The following is a description of a gene set: Human Gene Set: MODULE_301 studied in species Homo sapiens Genes in the cancer module 301., and this is the list of marker genes: HDAC9, ABCC5, GLRA3, IL24, BLOC1S5, COA7, ZNF423, KLHL41, NACAD, MED12L, SELP, PRKCB, NEK11, ZNF395, ANKRD28, FCRL1, TSPOAP1, SPRR1A, ZFP36L2, TCL1A, KIAA0753, FADS3, NTRK3, PLAC8, ADGRE2, MTBP, TASL, HEATR6, SPPL2A, ATP2A3, CSMD2, PTPRO, FLRT2, RSAD2, IGHG3, TRAF3IP3, UNC5D, TAP1, RIPOR3, RAX2, SEL1L, IRF8, TCF7, CD24, VANGL1, IGHM, KCNQ5, BACH2, GABBR1, SPINT2, NR2E1, OAS1, BCL2, PORCN, SLC27A5, FCER2, ADAM28, KCNA3, PNRC1, POLR3B, TTLL2, TXLNGY, NAALADL1, OSBPL10, CMKLR1, UTY, TRAPPC13, SPON2, MX1, RIPK4, NRIP2, MECP2, IL1R2, P2RY10, ZNF587, ZFHX2, SLC24A3, PRMT3, COL4A4, AMD1, FANCF, DBP, RABIF (NCBI Gene Id 5877), DLC1, DGKD, HSD17B11, ZNF292, BANK1, HVCN1, CD5, DEFA1, HDLBP, CD200, MARCHF1, LRRC19, CNR2, ROR1, TRDD3, DIRAS2, VAV1, HIKESHI, HMGN3, COQ9, IL4R, FOXP1, RUBCNL, SMCHD1, TXNIP, CXCR4, ADA2, IL10RA, BLK, SHC2, TP53I13, TNFAIP2, FCRL2, C3orf36, DPEP2, CTSF, FAM53B, XIRP1, CTSZ (cathepsin Z), CTLA4, CDC25B, DNAH11, RAPGEF6, USP2, CACNG4, MED29, MAP2K6, FCRLA, COL19A1, SOX6, LBH, RPAP3, ITGB7, FGR, PTPN12, CCDC186, STK33, PLGLB2, FAM200C, FCMR, SPATA20, G6PC3, ALOX5, TSPAN32, PTCRA, PDE2A, ITM2C, TMEM97, PLGRKT, BIN2, TOR1B, ARHGAP25, HLA-DRB3, RCSD1, MED25